The following is a description of a gene set: Human Gene Set: CASORELLI_ACUTE_PROMYELOCYTIC_LEUKEMIA_DN species: Homo sapiens from publication Casorelli I, Tenedini E, Tagliafico E, Blasi MF, Giuliani A, Crescenzi M, Pelosi E, Testa U, Peschle C, Mele L, Diverio D, Breccia M, Lo-Coco F, Ferrari S, Bignami M (PMID 16990782) Genes down-regulated in APL (acute promyeolocytic leukemia) blasts expressing PML-RARA fusion compared to normal promyeloblasts. Acute promyelocytic leukemia (APL) is a clonal expansion of hematopoietic precursors blocked at the promyelocytic stage. Gene expression profiles of APL cells obtained from 16 patients were compared to eight samples of CD34+-derived normal promyelocytes. Malignant promyelocytes showed widespread changes in transcription in comparison to their normal counterpart and 1020 differentially expressed genes were identified. Discriminating genes include transcriptional regulators (FOS, JUN and HOX genes) and genes involved in cell cycle and DNA repair. The strong upregulation in APL of some transcripts (FLT3, CD33, CD44 and HGF) was also confirmed at protein level. Interestingly, a trend toward a transcriptional repression of genes involved in different DNA repair pathways was found in APL and confirmed by real-time polymerase chain reactor (PCR) in a new set of nine APLs. Our results suggest that both inefficient base excision repair and recombinational repair might play a role in APLs development. To investigate the expression pathways underlying the development of APL occurring as a second malignancy (sAPL), we included in our study eight cases of sAPL. Although both secondary and de novo APL were characterized by a strong homogeneity in expression profiling, we identified a small set of differentially expressed genes that discriminate sAPL from de novo cases., and this is the list of marker genes: SMS, MACROD1, MTREX, CAMK1, ETFB, NAXD (NCBI Gene Id 95526), COPZ2 (COPI coat complex subunit zeta 2), KBTBD2, RPL3, VDAC1, BLMH, HNRNPA2B1, ASL, NONO, CLGN, ESPL1, PAFAH1B3, CDC123 (NCBI Gene Id 8872), HNRNPM, GTSE1, PRDX4, PAICS, VCL, INSIG1, AASS, PLS1, LSM14A, ZWINT, PDHB, HNRNPU, SEPTIN2, TECR, NADSYN1, CHTOP, MEIS1, CD24, CAPZA2, PSMD13, MGAT3, TUBB, SERPINB6, NCAPH, ILRUN, ARHGAP6, CHEK1, GOT1, AACS, RANGAP1 (NCBI Gene Id 6381), ATP5IF1, LMAN2 (NCBI Gene Id 10960), RPE, FZD6, DHTKD1, UTP14A, HTATIP2, PROS1, FANCI, PSTPIP2, SERBP1, RAD54L, SLC16A3, PPAN, SNF8, TLCD3A, NCAPH2, DDX18, C3orf52, APOBEC3C, SNX5, SLC25A4, ELOVL6, CLEC2B, KIFAP3, CENPE, TTC27, BUB1B, TSR2, SOCS2, SPINT2, WDR46, AATF, ENPP4, YKT6, HSPA4, JAKMIP2, PSMC3, HLA-DRB1, CCT5, VPS37C, NTRK1, HNRNPA3P1, NUP155, TSR1 (TSR1 ribosome maturation factor), SAMM50, PFKP, MELK, NCBP1, TIMM44, DVL2, CCNA2, ENO1, SRSF3 (serine and arginine rich splicing factor 3), PPID, SRI, AARSD1, SUMO1, TCAF1, HMGCR, STXBP6, UPF1, RAPGEF6, RAD23B, MRPL12, PAWR, HEATR6, MAPK14, HNRNPK, TCF4, FHL2, POLD2, TAF15, NOC3L, DYNC1LI1, TAL1, SNX17, SERINC3, SNRNP40, NXF3, HSPD1, MTMR2, PFKM, YBX1, GLUD1, SFPQ, NRIP1, TMEM176B, GINS4, ENSA, EPX, ENO3, XRCC5, PSMB5, MVD, PCYT2, CHAF1A, TRIP6, TIMM50, FILIP1L, QPRT, HNRNPF, KDM5D, RTN3, CC2D1A, NNT, ALDOC, KIF20A, KLF1, RRP1, SNU13 (NCBI Gene Id 6743), NAP1L4, MRPS10, WARS1, ACAT1, IL18BP, CD84, VWA5A, RYK, HNRNPA1, GP1BB, GALE, TEDC2, GFI1B, HNRNPAB, PSMA1, DHX15, FAM124B, LIN7C, ILF3, SAFB, DSCC1, EIF2B5, RAD54B, ACSL3, EIF5B, PES1, CTSL, INPP4B, CCT7, GMPS, NDUFS2, AIFM1, CKS1B, HSPA9, UQCRC1 (NCBI Gene Id 7384), BIRC5, ENO2, FBN1, PPM1G, TOP2A, GINS1, ECI2, TMEM97, ALDOA, EXOSC2, LPIN1, CDC6, GGA2, PICALM, BRCA1, PKIA, MLLT3, DLEU1, SNRPB, ADAM28, POLA2, PSMB6, HOXA10, FKBP4, DHFR, CBR1, XRCC6, ARHGAP19, FDPS, PPA1, GNAI1, MEF2C, ACTR3, ITGA2B, HNRNPH2, CENPF, RADX, PLA2G4A, CDKN3, HSD17B4, FLOT1, TBL3, CREB3, CYP51A1, RMND5B, TRO (trophinin), LARP4B, SPAG5, RAB33A, HNRNPC, RALY, PPIB, NME1, ASH2L, SEC24C, TIMELESS, VNN2, GTF2H3, DEPDC5 (NCBI Gene Id 9681), ACADVL, ALDH1A1, CENPM, SKAP2, PDIA3, AURKA (NCBI Gene Id 8465), CTNNBL1, PIN4, SLC25A1, FAM30A, TMEM14A, ICAM4, SLC2A6, DNPH1, PEX2 (NCBI Gene Id 5828), PIM1, GLUL, SCRN1, SNX4, CD2BP2, DSG2, DLGAP5, KPNA2, PTK2, CLN6, RBFOX2, NEK9, MYH10, DAG1, CD59, SMC4, BEX3, RFC4, RABGAP1, NASP, ACTB, HMGA2, CCNB2, MCM7 (minichromosome maintenance complex component 7), VOPP1, RRP9, LAPTM5, SCD, EIF5A, RECQL5, GPSM2, PRSS23, CKAP4, HNRNPA1P3, ECI1, EXOC3, ASB8, BLVRA, ODC1, GATA2, HELLS, MKI67, ZNF671, DLAT, HDC, THG1L, TFR2, TUFM, TARDBP, TRAFD1, TFPI, CDC20, DKC1, NFIB, SWAP70, PPP2R1B, PGD, HOXA9, G3BP2, KIF11, SLC22A17, TYMS, RBL1, PAF1 (PAF1 homolog, Paf1/RNA polymerase II complex component), PPP1R10, IDI1 (isopentenyl-diphosphate delta isomerase 1), KDM1A, DPP4, TPD52, RRM2, KDELR2, ZNF175, NOLC1, CDC25C, IL9R, REX1BD, EIF2S3, CDK9, GGCT, ABCC4, SNRNP25, PIR, THBS1, BEX1, ILKAP, RAB3GAP1, CD40, IVNS1ABP, ABLIM1, TIMP3, CTDSPL, ACTR2, UPF3A, KIF2C, CDC45, LUC7L2, ACAT2, GLOD4, EIF2S2, OPTN, KIFC1, CLC, SHMT2, SV2A, MREG, DDAH1, GALNT12, STIL (NCBI Gene Id 6491), DHCR24, DNAJC12, PSMC3IP, PSAT1, DNAJC6, WDHD1, RFC3, HNRNPH3, PCYT1B, DDX41 (NCBI Gene Id 96647), EIF1AY, MSMO1, ECHDC1, NSDHL, AAGAB, HSP90AB1, CHCHD3, GUCY1B1, CSE1L, FUS (NCBI Gene Id 406232), CDC25A, NDUFV1, MAD1L1, LDHB, FAM174B (NCBI Gene Id 400451), COA7, COIL, KIF15, LRRFIP2, EIF3B, INPP1, CDHR1, KIF4A, HNRNPD, VRK1, CYC1 (cytochrome c1), VCP, SLC27A2, THOC6, ARID5B, PRR11, ADIPOR2, HOXA7, PRC1, ENTPD6, TADA2A, CLCN4, SLA, TK1, SRSF9, AKR1B1, ASPM, ROCK2, PRMT7, DNAJC8, LUC7L, POLD3, CHEK2, BAZ1B, SQLE, HMGCS1, CEPT1, TJP2, DHCR7, HDGFL3, HNRNPA3, AP2M1 (adaptor related protein complex 2 subunit mu 1), SSRP1, PLOD2, LMNA, DPPA4, SRP54, RPN1, CHMP4A, JPT2, TBC1D31, CCNB1, MECOM, EXOSC4, STOM, SLC18A2, NEK2, NUDC, ELOVL5, TST, SEMA3C, LDLR, BAX, TM7SF2, RCC1L, NPR3, DHX9, LIF, PDK3, HNRNPUL2, ERO1A, STON1, LUC7L3, CSF2RB, NUDT11, EPB41L2, MUC1, CAVIN1, NANS, NDUFS6, ARL6IP4, EID1, NEFH, PDIA6, CMAS, ARPC4, HPGDS, ARFGAP2 (NCBI Gene Id 84364), ZNF544, ARF3, RPS4Y1, BCAP31, RPA1, MCM3, ROBO1, FADS1, EPRS1, HIRIP3, GLO1, CARMIL1, SDHA, ELP3, GINS2, STT3A, G3BP1, SLC38A1, ACOT2, ACACA, MRM2, DLC1, ERG28, C10orf95-AS1, LMO4, NCAPG, PRKAR2B, SQSTM1, BMAL2, RDX, PTGS1, RNASE2, NPM1 (nucleophosmin 1), MYDGF, HMCES, CDC42BPA, HADH, GK, KEAP1, KYNU, CYP1B1, HPGD, APOC1, ABCF2, ATIC, TIMM10, HSP90AA1, LGALS8, ACP1, TMBIM1, ATP6V0D1, FDFT1, DNM1L, ACLY, DNAJC9, FEM1B, APIP, CSRP1, LOX, FAM111A, ENOSF1, MAPRE2, PIK3R3, FADS2, SNRPA1, DCXR, FUBP1, EBP, LMNB2, ST7, LMO2, SLC27A5, IDH3B, GSS, FZD5, TUBB2B, MRPL28, MAP7, SHQ1, EIF4E2, CDK1, GRPEL1 (GrpE like 1, mitochondrial), RECQL4, LAPTM4B, TTLL12, NUSAP1, SNRNP70, TRAP1, NDN, HLA-DPA1, SRPK2, MCM2, STIP1, DDX3Y, POGLUT2, STX7, KPNB1, RDH11, FEN1, MCM4, DUS4L, TMEM106C, HADHA, CTPS1, TBC1D4, SLF2, PRG2, SF3A3, PRPF4, TACO1, PGK1, PNRC2, TPM1, GAPDH, CEP15, AARS1, FAM171A1, SERPINE2, BUB3, MRM3, LSS, HPS4, COA1, HMMR, DNAJC17, TPI1, LDHA, AURKB, MCM5, BACE2, M6PR, NUP93, RAP2B, VWF, QTRT1, COQ3, HEXIM1, FOXM1, PLEKHB2, ACOT9, NUDT1, NCF1, CIRBP, TRIP13, PTGES2, PFKL, ACIN1, UROS, LAT, EED (embryonic ectoderm development), POLQ, IP6K1, ILVBL (NCBI Gene Id 95885), SFXN1, NDC80, EDC3, CDC5L (cell division cycle 5 like), CEP55, PUS1, LAMP1, KLHDC3, CENPA, SNRPN, MMRN1, PLK1 (NCBI Gene Id 5347), LPCAT3, SLC2A10, AKR1C1, CTSZ, HMGB3, ETS2, KIF22, EIF2S1, APOL3, YWHAH, ALB, GARS1, MAOA, ORC1, SSR1